Given this list of marker genes WNT2B, LRRK2, FOXD3, PRKCD, PPP2R2A, PPP2R1A, PTPA, CD44, FBXW2, AXIN1, FZD5, PPP2R5E, CREBBP, DVL2, TCF7L2, FZD7, RACGAP1 (NCBI Gene Id 94651), WNT3, PRKCG, NLK, DVL3, FZD9, PPP2R2C, LEF1 (lymphoid enhancer binding factor 1), NANOG, WNT7B, WNT9B, JUN, WNT2, TP53, WNT10A, CCND2, NKD1, WNT1 (NCBI Gene Id 7471), CTNND1, AXIN2, PRKD1, RHOA, FZD8, PAFAH1B1, ZBTB33, PLAU, PPP2CA, CTBP1, TCF7L1, CCND1, LDLR, WNT11, APC, WNT5B, PPP2R1B, PRKCH, PRKCI, PPP2R5C, NFYA, CTBP2, NKD2, PPP2R3A, MMP7, WNT7A, PPM1J, WNT6, FZD2, FZD4, PRKCB, PPP2CB, MAP3K7, PPP2R2B, WNT4 (NCBI Gene Id 54361), LRP5, EP300, MAP2K4, PRKCQ, GSK3B, FZD1, PRKCE, MYC, PRKCZ, WNT5A, DVL1, ESRRB, WNT10B, SOX2, CTNNB1, FZD10, PRKCA, CCND3, WNT3A, WNT16, LRP6, FZD3, PPP2R3B, MAPK9, FOSL1, POU5F1, FRAT1, PPARD, TCF7, MAPK10, FZD6, CSNK1E, here is a description of the gene set: Wnt signaling and pluripotency Human Gene Set: WP_WNT_SIGNALING_AND_PLURIPOTENCY species: Homo sapiens